Given this list of marker genes STAT4, PPP3R1, IFNA17, IL2RB, IFNA14, PPP3CA, FOSL1, FOS (Fos proto-oncogene, AP-1 transcription factor subunit), TNFRSF18, TNF, MAPK9, PRKCQ, KRAS, PPP3CB, B2M, MAPK1, PRKCB, CD3E (CD3 epsilon subunit of T-cell receptor complex), PRKCA, IL2RA, CD8A, IFNA21, BRAF, CD8B, TNFRSF4, EGR4, RAF1, FASLG, JUNB, IFNA10, IFNA6, PRF1, NFATC2 (nuclear factor of activated T cells 2), MAP2K1, IFNG, HLA-A, MAPK8, MAPK3, MAP2K2 (mitogen-activated protein kinase kinase 2), PRKCE, NFATC1, CD247, IFNA5 (NCBI Gene Id 89952), CD3G, IFNA7, HRAS, EOMES, IFNAR1, NRAS (NRAS proto-oncogene, GTPase), JUN, IFNA16, IFNA1, CD3D, IFNAR2 (NCBI Gene Id 3455), ELK1, IFNA8, IFNA2, IFNA4, IL2, TNFRSF9, PTPN7, NFATC3, IL2RG, GZMB, EGR1, here is a description of the gene set: studied in species Homo sapiens Downstream signaling in naïve CD8+ T cells from publication Schaefer CF, Anthony K, Krupa S, Buchoff J, Day M, Hannay T, Buetow KH (PMID 18832364) Human Gene Set: PID_CD8_TCR_DOWNSTREAM_PATHWAY